Given this list of marker genes EMC10, TBL1X, TREX1, TMEM163, HNRNPC, SPTBN1, POLG, HERC2, DYM, ADA2, TWNK, ERF, here is a description of the gene set: studied in species Homo sapiens Diminished ability to concentrate The inability to focus or concentrate on a specific task, activity, or object. The subject may find themselves unable to grasp or understand written text and re-reads frequently without understanding. Familiar tasks or activities are severely compromised due to the lack of ability to concentrate. Thinking through multi-step problems is typically very difficult or impossible, leading to avoidance of such activities. Human Gene Set: HP_DIMINISHED_ABILITY_TO_CONCENTRATE